Given this list of marker genes EIF3I, GCN1, EEF1A1 (NCBI Gene Id 96648), EIF2B5, EEF1A2, GFM1, EIF2B4, EIF2S1, CPEB3, EIF3J, EIF4E, EIF5A2, EIF3D, GFM2, EEF1G (eukaryotic translation elongation factor 1 gamma), EIF2D, EEF2K, EIF3F, EIF3A, MTRF1L, GTPBP1, MTRF1, EIF4A1, EIF3E, EIF4B, EIF4G2, AGO2, EEF1A1P5, EIF3H, EIF5AL1, EIF6, CPEB2, EIF3G, EIF1, COPS5, EIF3CL, EIF2S3B, EIF5, CPEB1, MTIF3 (mitochondrial translational initiation factor 3), EIF1AD, EIF3L, EIF2B1, EIF4G3, GSPT1, EEF1B2, EIF2B3, MTRFR, GTPBP2 (NCBI Gene Id 54676), ABTB1, EIF4E3, EIF3M, DHX29, EIF3K, EIF1AX, HBS1L, EIF4H, EIF1B, EIF4E2, MRPL58, GSPT2, EIF5B, EIF1AY, TUFM, EEF2, EIF3C (NCBI Gene Id 8663), EFL1, EIF2A, EIF4G1, DENR, EIF2B2, MCTS1, EIF5A, EIF4A2, CPEB4, EEF1D, MTIF2, EIF4E1B, EIF2S3, ETF1, EEFSEC, ABCF1, TSFM (NCBI Gene Id 10102), EIF2S2, EIF3B, here is a description of the gene set: A molecular function required for translation of a mRNA into a protein functioning as part of initiation, elongation or termination of translation. Human Gene Set: GOMF_TRANSLATION_FACTOR_ACTIVITY studied in species Homo sapiens